The following is a description of a gene set: Human Gene Set: HP_IMPAIRED_ANTIGEN_SPECIFIC_RESPONSE Impaired antigen-specific response An impaired immune response mediated by cells expressing specific receptors for antigen produced through a somatic diversification process, and allowing for an enhanced secondary response to subsequent exposures to the same antigen (immunological memory). studied in species Homo sapiens, and this is the list of marker genes: SASH3, CTNNBL1, CD81, ALG12, NSMCE3, IKBKG, IGKC, PRKCD, REL, PGM3, RAC2, CD79A, LCP2 (NCBI Gene Id 3937), MAGT1, IRAK4, TNFRSF13B, CARMIL2, RAG2, ICOS, TCF3, SHARPIN, POLD1 (DNA polymerase delta 1, catalytic subunit), ADA, CTPS1, CORO1A, COG6, PMM2, RNF31, KNSTRN, TNFRSF9 (TNF receptor superfamily member 9), SLC35C1, FAS, TNFRSF13C, B2M, WAS, PIK3CD, IRF2BP2, IL2RA, ARHGEF1, FASLG, DOCK2 (NCBI Gene Id 1794), CASP10, IGHG2, CBLB, LRBA, CD19, CR2, ZAP70, CARD11 (NCBI Gene Id 84433), RFXANK, SEC61A1, CD70, RIPK1, MALT1, CD247, BTK, CASP8, RAG1, HYOU1, AICDA